Given this list of marker genes LCTL, SERPINF1, PPP1R13L (NCBI Gene Id 23453), CRB1, MAN2A1, IGF1, BFSP1, RAB11FIP4, WNT6, TGFB1, SOX12, INTU, STRA6, FGFR2, CITED2, TMC1, TMOD1, LGR5, DLX1, BHLHE23, WNT9B, SOX9, ESRP1, TBC1D32, FREM2, SLITRK6, HMX2, OLFM3, BMP4, RAB18, SMG9, HMGB1, DLG1, FAT1, IFT140, GRXCR1, RAB3GAP1, GABRB2, JAG1, FZD6, MITF, BCL2L11, PJVK, REST, CRYGC, COL8A2, TFAP2A, WNT5B, WNT9A, SMOC1, DLL1, SPRED2, ABCB5, PITX3, CLDN3, CTNNB1, INTS15, MFRP, OSR1 (odd-skipped related transcription factor 1), FBN2, PPP2R3A, HOXA13, INHBA, TSPAN12, FOXF2, MCOLN3, MFN2, KDM5B, TRAF3IP1 (TRAF3 interacting protein 1), PAX4, CC2D2A, WNT1, MYH15, RPGRIP1L, CRYAA, ZEB2, HES1, WT1, B9D1, AGTPBP1, CDKN1C, DLL4, FZD4, MED1, CRYBA2, FOS, ATP8B1, LHX3, OLIG3, LRP10, TPRN, TBX18 (NCBI Gene Id 9096), SIX4, PDE6B, CRYGN, RARB, CRYBB3, LRIG3, JMJD6, LIN7A, CHRNA10, LHX1 (NCBI Gene Id 3975), NHERF1, NOX3, PBX1, POU3F4, XRN2, MYO3A, MYCN, SLC17A6, NOTCH1 (NCBI Gene Id 54781), WNT7B, PXDN, SOD1, PRPH2, PAX8, TULP3, PROX1, BMPR2, TGIF1, BCL2, IMPG2, FZD3, OC90, MTNR1B, NKX2-6, WNT10B, ECE1, AQP1, MAF, CRYGA, WNT7A, C1QTNF5, CDH23, LAMA1, TGFBR1, RPE65, EGFR, MEGF11, HIPK1, ANP32B, FAT3, GATA3, SLC6A3, MIP, ROR1, SPRED1, STOX1, WDR19, ABI2, PAX5, GRN (granulin precursor), ZIC1, ATF4, SHROOM2, LHFPL5, SOX2, LHX2, RARG, NPHP1, OTOP1, FGF20, PRICKLE1, PHACTR4 (phosphatase and actin regulator 4), ELP6, NF1, OSR2, TGIF2, SMCHD1, TCIRG1, ACTL6A, COL8A1, SKIL, VIM, SOS1, HAND2, DSCAM, POU4F3, VAX1 (ventral anterior homeobox 1), NF2, ATP2B4, FOXL2, CDK20, PRRX1, CCM2, MCM2, MAPK1, SLC4A5, PLAAT1, ATP6V1B1, HCN1, SAMD7, EYA1, ZIC3, IRX5, STAT3, CYP26B1, BSG, TSKU, PTPRM, CYTL1, GLI3, SLC26A5, CELF4, TBX1, VSX2, RPL24, BCAR3, EPHA4, DLX2, IHH, BAX, NRP1, PLPPR4, NEUROG1, ELMOD3, MEIS1, ZDHHC16, ARSG (arylsulfatase G), BMPR1B, GDF3, MTERF4, TRIP11, SMAD3, SLC25A25 (solute carrier family 25 member 25), PDE6A, MINAR2, LIMK2, KERA, TBX2, IFT122, FOXN4, RDH13, LIM2, SLC4A7, CRYBA1, OLIG1, PRSS56, MAFB, COL11A1, SDK2, INSIG2, PHOX2B, IFT20, GET1, RP1L1, FRZB, POC5, MAPKAPK2, DDR1, ATOH1, OTOL1, EPHB2, DRAM2, SLC44A4, SIX6, MYF5, GPM6A, CECR2, SCO2, SOBP, CLN8, RS1, CLRN1, EYA4, FSCN2, NEUROG2, KCNQ1, PI4KB, PFDN5, THY1, SOX8, WNT16, DLX5, ATOH7, BAK1, PER2, MYO6, VEGFA, DVL2, CTNS, MEIS3, FKBP8, MYO7B, ADAMTS18, BCL11B, OPN5, CALB1, RPGR, SPARC (NCBI Gene Id 6678), MERTK, TCAP, NTF4, PTF1A, HSF4, KCNQ4, PTPN11, MFAP5, NR4A3, TENM3, NR2E1, ADAM10, LAMC3, CRYAB, ACVR2B, TCF15, EDN1, TGFBR2, PDGFRB, TSHZ1, TMEM231, HESX1, RAC1, PLAAT3, NPHP4 (NCBI Gene Id 261734), USH2A, CLRN2, BBS4, STAU2, MAPK3, MYOM2, TMEM132E, MDM1, CRX, SOX4, CDON, HES5, KCNK2, RBP4, OLIG2, LENEP, RPL38, CPAMD8, KRT12, CYP1A1, SPRED3, HOXA2, BMP7, FGF9, ALDH1A2, NOTCH2, ARL6, SRF, CRYGS, WHRN, PKNOX1, SALL2, SLC39A5, CASP2, RING1, SCAPER, GRM6, BMP2, VSTM4, AHI1 (NCBI Gene Id 54806), TTC39C, NES, MYCL, IFT27, RPGRIP1, CDKN1B, GNB1, FOXC2, FOXE3, VANGL2, MPV17, GJE1, RRM1, CLIC4, MYO3B, EDNRA, DTNBP1, ATG5, JAG2, HPN (hepsin), MFAP2 (NCBI Gene Id 4237), USH1C, CRYBB2, TIFAB, WNT5A, GPD2, CLCN2, FGFR1, MEIS3P1, NHS, B3GLCT, PCDH15, CRYGB, PYGO2, MKS1, OTX1, POU4F2, ADAMTS9, SOX1, PBX4, NRL, FZD2, SLC38A8, SPRY2 (NCBI Gene Id 10253), FJX1, GNG8, FZR1, ATP8A2, ZHX2, DLX6, ACVRL1, RAB37, HMX3 (H6 family homeobox 3), GSDME (NCBI Gene Id 1687), SLC25A27, SDK1, ASCL2, SOX11, ACHE, HDAC1, NEUROD1, NECTIN3, EFEMP1, PITX2 (paired like homeodomain 2), SLC17A7, ANKRD24, PAX2, GABRB3, TUB (TUB bipartite transcription factor), RHO, TRIOBP, OPN4, FLT1, TMEM135, GRXCR2, MFSD8, BIRC7, FGF10, MFSD2A, SIX1, SMARCD3, SEC24B, COL4A1, ZNF513, GABRA5, KCNK3, DRD2, FOXP2, GSC, EPHA2, RAX, CCNA2, INSIG1, COL5A1, SIPA1L3, FGF8, NR2E3, BFSP2, COL2A1, RCN1, KDM2B (lysine demethylase 2B), AQP5, NFIB, USH1G, NTRK3, BNC2, SCRIB, FOXI1, CRYBB1, DZANK1 (NCBI Gene Id 55184, double zinc ribbon and ankyrin repeat domains 1), CACNA1S, LAMB2, WNT2B, BBS1, SMARCA4, ALDH1A3, DIO3, KLF4, CEBPD, MYC, RD3, CHRNA9, UNC45B, CNTF, HEY2, NTN1, BLOC1S5, MAB21L1, LPCAT1, BMPER, NFIA, COL5A2, NEUROD6, VAX2, MYO15A (NCBI Gene Id 51168), GRHL3, GATA2, BMP5, TFAP2B (NCBI Gene Id 7021), PBX3 (NCBI Gene Id 5090), SOX3, GNAT2, CRYBG3, SLC1A1, PAFAH1B1, HIF1A, TGFB2, MAB21L2, BHLHE22, NDP, MYH10, TTLL5, NOG, PROM1 (NCBI Gene Id 9634), OTOGL, RORB, LARGE1, PBX2, FKRP, SKI, BHLHA15, HOXC13, CTHRC1, CABP4, IFT172, ATF6, SIX3, GJB6, GDF11, DCX, SH3PXD2B, CHRDL1 (chordin like 1), SIX2, ZEB1, BMP6, TTC8, CEBPA, CYP1B1, PLS1, HOXA1, WDPCP, TECTA, NKD1, CLDN19, ANGPTL7, LRP5, RBPJ, FZD5 (NCBI Gene Id 81561), CACNA1C, BBS10, LEF1, RARA, GNGT1 (G protein subunit gamma transducin 1), GNAT1, DIAPH3, YY1, GBX2, KDR, ARHGAP35, TWIST1, HIPK2, TH, HDAC2, ESRRB, VSX1, BARHL2 (BarH like homeobox 2), JUN (Jun proto-oncogene, AP-1 transcription factor subunit), CEP290, SDC4, CHD7, SIX5, PTK7, DCHS1, MEIS2, NEUROG3, BBS7, NAGLU, TMEM215, STRC, ADGRV1, TBC1D20, FOXC1, RP1, HMGN1, ITGA8, PDE6C, FBN1, NKX3-2, PRKCI, MSX1, TDRD7, NECTIN1, SHH (sonic hedgehog signaling molecule), CRB2, DCANP1, WNT2, SAMD11, C12orf57, ATG4B, SP3, ARHGEF15, FGF2, CRYBA4, GJA8, WNT10A, BCR, TULP1, USP45, WNT3A, PDGFRA, GRHL2, BLOC1S3, THRB (NCBI Gene Id 7068), ROM1, SLC17A8, CRYGD, PAX6, NTRK2 (NCBI Gene Id 4915), RDH10, FRS2, LRIG1, DVL1, SPRY1, TMIE, PRDM1, RHOJ, PDZD7, NIPBL (NIPBL cohesin loading factor), HPCA, PSEN1, IFT88, ASCL1, EPHB1, MYOM1, KIT, FOXG1, TBX3, MYO7A, FASLG, TWSG1, NEUROD2, NEUROD4, PRKRA, here is a description of the gene set: Human Gene Set: GOBP_SENSORY_ORGAN_DEVELOPMENT species: Homo sapiens The process whose specific outcome is the progression of sensory organs over time, from its formation to the mature structure.